The following is a description of a gene set: Reactome Pathway: Response of EIF2AK1 (HRI) to heme deficiency species: Homo sapiens The kinases of the integrated stress response phosphorylate EIF2S1 (eIF2-alpha) to regulate cellular translation. The kinases comprise PERK (also called EIF2AK3), which responds to unfolded protein in the endoplasmic reticulum; EIF2AK2 (also called PKR), which responds to cytosolic double-stranded RNA; EIF2AK4 (also called GCN2), which responds to amino acid deficiency; and EIF2AK1 (also called heme-regulated inhibitor, HRI, and heme-controlled repressor, HCR), which responds to heme deficiency and cytosolic unfolded protein. Each molecule of EIF2AK1 binds two molecules of heme, one bound near the N-terminus and one bound at the kinase insert (KI) domain that inhibits the kinase activity of EIF2AK1 (inferred from the rabbit homolog in Chefalo et al. 1998, Rafie-Kolpin et al. 2000, inferred from the mouse homolog in Misanova et al. 2006, Hirai et al. 2007, Igarashi et al. 2008). Dissociation of heme from the KI domain activates the kinase activity of EIF2AK1, which autophosphorylates (inferred from the mouse homolog in Bauer et al. 2001, Rafie-Kolpin et al. 2003, Igarashi et al. 2011) and then phosphorylates EIF2S1.<br>Phosphorylated EIFS1 causes a reduction in general cellular translation and thereby coordinates globin synthesis with heme availability during erythropoiesis (inferred from mouse knockout in Han et al. 2001, reviewed in Chen et al. 2014). Translation of mitochondrial and cytosolic ribosomal proteins is most severely reduced, causing a decrease in cellular protein synthesis (inferred from mouse homologs in Zhang et al. 2019). Lack of EIF2AK1 causes accumulation of unfolded globins devoid of heme and consequent anemia in iron-deficient mice (inferred from mouse knockout in Han et al. 2001). Activation of the cytoplasmic unfolded protein response and impaired mitochondrial respiration are also observed in HRI deficiency (inferred from mouse homologs in Zhang et al. 2019).<br>Phosphorylation of EIFS1 activates translation of certain mRNAs such as ATF4, ATF5, and DDIT3 (CHOP) that have upstream ORFs (inferred from mouse homologs in Harding et al. 2000). ATF4 in turn activates programs of gene expression that ameliorate effects of the stress to maintain mitochondrial function, redox homeostasis, and erythroid differentiation (inferred from mouse homologs in Zhang et al. 2019). Unresolved stress, however, can eventually lead to apoptosis regulated by DDIT3. EIF2AK1 also represses mTORC1 (mechanistic target of mechanistic target of rapamycin complex 1) signaling via ATF4-mediated induction of GRB10 as a feedback mechanism to attenuate erythropoietin-mTORC1-stimulated ineffective erythropoiesis in iron deficiency anemia (inferred from mouse homologs in Zhang et al. 2018 and Zhang et. al. 2019).<br>EIF2AK1 is also activated by heat shock, arsenite (oxidative stress), and osmotic stress (inferred from mouse homologs in Lu et al. 2001). The mechanisms by which these stresses act on EIF2AK1 are independent of heme but are not yet fully elucidated. Furthermore, EIF2AK1 is involved in the production of human fetal hemoglobin, and EIF2AK1-mediated stress response has emerged as a potential therapeutic target for hemoglobinopathies.<br>In addition to regulation of erythropoiesis, EIF2AK1 shows effects outside of the erythroid lineage, including requirement for the maturation and functions of macrophages (inferred from mouse homologs in Liu et al. 2007), reduction in endoplasmic reticulum stress in hepatocytes, activation of hepatic expression of fibroblast growth factor, and mediation of translation of GRIN2B (GluN2B. a subunit of the NMDA receptor) and BACE1 in the nervous system. HRI-integrated stress response is activated in human cancer cell lines and primary multiple myeloma cells, and has emerged as a molecular target of anticancer agents. part of: Cellular responses to stress, and this is the list of marker genes: ATF4, GRB10, PPP1R15A, ASNS, DDIT3, EIF2S1, EIF2S2, CEBPB, ATF5, CHAC1, TRIB3, EIF2S3, CEBPG, EIF2AK1, ATF3